Given this list of marker genes Nherf1, Cdc42, Copg1, Ripor1, Pdcd10, Arhgap21, Stk25, Ywhaz, here is a description of the gene set: Mouse Gene Set: GOBP_ESTABLISHMENT_OF_GOLGI_LOCALIZATION The directed movement of the Golgi to a specific location. studied in species Mus musculus